Given this list of marker genes KCNJ18, SLC12A3, CLCNKB, SERPINA6 (serpin family A member 6), GABRA3, CACNA1S, here is a description of the gene set: A decreased concentration of potassium(1+) in the urine. Human Gene Set: HP_DECREASED_URINARY_POTASSIUM studied in species Homo sapiens Decreased urinary potassium